The following is a description of a gene set: Any process that modulates the frequency, rate or extent of the chemical reactions and pathways resulting in the formation of carbohydrates. studied in species Mus musculus Mouse Gene Set: GOBP_REGULATION_OF_CARBOHYDRATE_BIOSYNTHETIC_PROCESS, and this is the list of marker genes: Pth, Adcyap1r1, Usp7, Egf, Ntsr1, Erfe, Fbp1, Gcg, Pth1r, Cyp2j6, Mup5, Ppp1r3c, P2ry6, Arpp19, Mup3, Ppp1r3a, Akt1, Ppp1r3d, Pdgfb, Ap2a1, Inpp5k, Il6, Gpt, Ptger4, Gnmt, Tcf7l2, Ppp1r3b, Wdr5, Zfp692, Prkag2, Gsk3b, Myh9, Lep, Ppp4r3a, Nfkb1, Ep300, Foxo1, Mst1, Hnf4a (hepatic nuclear factor 4, alpha), Ins1, Sirt6, Dgat2, Acadm, Pou1f1, Ppp4r3b, Grb10, Obp2a, Sirt1, Mup1, Avpr1b (NCBI Gene Id 26361), Dgkq, Lepr, Nnmt, Ppara (peroxisome proliferator activated receptor alpha), Akt2, Pdk2, Snca, Serpina12, Hif1a (hypoxia inducible factor 1, alpha subunit), Prkag3, Nln, Has2, Plcd1, Enpp1, Ranbp2 (RAN binding protein 2), Mup11, Pask, Mas1, Kat2a, Prkag1, Cltc, Xpc, Igf1, C1qtnf2, Cry1, Prkg1, Clk2, C1qtnf3, Sesn2, 1810024B03Rik, Pfkfb1, P2ry1, Ins2, Plek, C1qtnf12, Epm2aip1, Mup2 (NCBI Gene Id 17841), Prkaca, Pgp, Mtcl2, Ppp1r3f, Gfpt1, Ppp1cb, Kat2b (K(lysine) acetyltransferase 2B), Mtor, Ppp1ca (NCBI Gene Id 19045), Cd244a, Oprm1, Lhcgr, Mup4 (NCBI Gene Id 17843), Slc35b4, Ptpn2, Ppp1r3g, Sorbs1, Nr3c1, Esrrb, Dyrk2, Smpd3, Irs1, Ogt, Ddb1, Sirt7 (sirtuin 7), Gper1, Supt20, Adipoq, Irs2, Igf2, Stk11, Insr, Ptafr, Ppp1r3e, Sik1, Gck (NCBI Gene Id 14624), Tgfb1